The following is a description of a gene set: studied in species Homo sapiens Reactome Pathway: Signaling by MET MET is a receptor tyrosine kinase (RTK) activated by binding to its ligand, Hepatocyte growth factor/Scatter factor (HGF/SF). Similar to other related RTKs, such as EGFR, ligand binding induces MET dimerization and trans-autophosphorylation, resulting in the active MET receptor complex. Phosphorylated tyrosines in the cytoplasmic tail of MET serve as docking sites for binding of adapter proteins, such as GRB2, SHC1 and GAB1, which trigger signal transduction cascades that activate PI3K/AKT, RAS, STAT3, PTK2, RAC1 and RAP1 signaling.<br>Activation of PLC gamma 1 (PLCG1) signaling by MET remains unclear. It has been reported that PLCG1 can bind to MET directly or be recruited by phosphorylated GAB1. Tyrosine residue Y307 of GAB1 that serves as docking sites for PLCG1 may be phosphorylated either by activated MET or SRC. Another PCLG1 docking site on GAB1, tyrosine residue Y373, was reported as the SRC target, while the kinase for the main PLCG1 docking site, Y407 of GAB1, is not known.<br>Signaling by MET promotes cell growth, cell survival and motility, which are essential for embryonic development and tissue regeneration. MET signaling is frequently aberrantly activated in cancer, through MET overexpression or activating MET mutations.<br>Considerable progress has recently been made in the development of HGF-MET inhibitors in cancer therapy. These include inhibitors of HGF activators, HGF inhibitors and MET antagonists, which are protein therapeutics that act outside the cell. Kinase inhibitors function inside the cell and have constituted the largest effort towards MET-based therapeutics.<br>Pathogenic bacteria of the species Listeria monocytogenes, exploit MET receptor as an entryway to host cells.<br>For review of MET signaling, please refer to Birchmeier et al. 2003, Trusolino et al. 2010, Gherardi et al. 2012, Petrini 2015. part of: Signaling by Receptor Tyrosine Kinases, and this is the list of marker genes: PIK3CA, TNS4, RAB4B, SRC, HGF, SPINT2, MUC20, GAB1, CRK, COL3A1, LAMA1 (laminin subunit alpha 1), PIK3R1, COL27A1, CBL, LRIG1, ITGA3, RAPGEF1 (NCBI Gene Id 2889), LAMC1, EPS15, STAT3, UBB, RAC1, LAMB3, STAM2, USP8, LAMA3, PTPN11, SH3GL1, SH3GL3, RPS27A, ITGA2, PTPN2, PTPRJ, COL2A1, PTPN1, COL1A2, MET, COL24A1, COL11A1, LAMA2, CRKL, HRAS, STAM, FN1, SOS1, SPINT1, DOCK7, COL11A2, GRB2, KRAS, HPN, SH3KBP1, RAP1A, HGS, ITGB1, RAP1B, UBA52, LAMB2, LAMC2, COL1A1, HGFAC, RANBP9, LAMA5, UBC, TNS3, LAMB1, RAB4A, GGA3, LAMA4, ARF6, RANBP10, LAMC3, COL5A1 (collagen type V alpha 1 chain), COL5A3, NRAS, SH3GL2, PTK2, COL5A2, SHC1